Given this list of marker genes ADK, SLC29A1, NT5C2, PNP, SLC28A2, NME2 (NCBI Gene Id 4831), SLC28A3, ADA, ITPA, SLC29A3, NME1, here is a description of the gene set: Ribavirin (RBV) is a synthetic nucleoside analog structurally related to guanine. It is given orally as part of the treatment of HCV infection, and by inhalation for the treatment of RSV infection. According to the WHO, ribavirin can also be used for the treatment of viral hemorrhagic fevers.<br>RBV is administered orally in doses of 400 to 600 mg. It is highly soluble in water and a typical dose is dissolved completely over a wide range of acidities. RBV is rapidly absorbed into the circulation. After the oral administration of 600 mg radiolabeled ribavirin, approximately 61% of the drug was detected in the urine and 12% was detected in the feces. 17% of an administered dose was in unchanged form. RBV accumulates in human erythrocytes and remains in the body for weeks, with a halflife of >100 hours. A consequence of the accumulation in erythrocytes is the well-known side effect of hemolytic anemia, which is reversible by cessation of administration (FDA label Rebetol, 2013).<br>Ribavirin is a prodrug. It is metabolized through two different paths: phosphorylation, yielding the active triphosphate (RBV-TP), and degradation via de-ribosylation and hydrolysis of the amide group. The GI tract, and not the liver, appears to be the major site of first-pass elimination. part of: Drug ADME Reactome Pathway: Ribavirin ADME studied in species Homo sapiens